Given this list of marker genes GCGR, CDKN1B, CDKN1A, MEN1, CDKN2C, CDKN2B, here is a description of the gene set: studied in species Homo sapiens Human Gene Set: HP_GLUCAGONOMA An endocrine tumor of the pancreas that secretes excessive amounts of glucagon. Glucagonoma